Given this list of marker genes KCNN3, MAP3K20, SMARCA4, NOG, ARID1B, here is a description of the gene set: Abnormality of the phalanges of the 5th toe Human Gene Set: HP_ABNORMALITY_OF_THE_PHALANGES_OF_THE_5TH_TOE studied in species Homo sapiens